The following is a description of a gene set: Human Gene Set: HARALAMBIEVA_PBMC_FLUARIX_AGE_50_74YO_CORR_WITH_28D_MEM_B_CELL_RESPONSE_AT_28DY_LATE_GENE_EXPR_INDIVID_GENE_MODELS_PRED_PEAK_B_CELL_ELISPOT_RESP_POSITIVE studied in species Homo sapiens from publication Haralambieva IH, Ovsyannikova IG, Kennedy RB, Zimmermann MT, Grill DE, Oberg AL, Poland GA (PMID 27317456) BACKGROUND: Studies suggest that the recall-based humoral immune responses to influenza A/H1N1 originates from activated memory B cells. The aim of this study was to identify baseline, early and late blood transcriptional signatures (in peripheral blood mononuclear cells/PBMCs) associated with memory B cell response following influenza vaccination. METHODS: We used pre- and post-vaccination mRNA-Seq transcriptional profiling on samples from 159 subjects (50-74years old) following receipt of seasonal trivalent influenza vaccine containing the A/California/7/2009/H1N1-like virus, and penalized regression modeling to identify associations with influenza A/H1N1-specific memory B cell ELISPOT response after vaccination. RESULTS: Genesets and genes (p-value range 7.92E(-08) to 0.00018, q-value range 0.00019-0.039) demonstrating significant associations (of gene expression levels) with memory B cell response suggest the importance of metabolic (cholesterol and lipid metabolism-related), cell migration/adhesion, MAP kinase, NF-kB cell signaling (chemokine/cytokine signaling) and transcriptional regulation gene signatures in the development of memory B cell response after influenza vaccination. CONCLUSION: Through an unbiased transcriptome-wide profiling approach, our study identified signatures of memory B cell response following influenza vaccination, highlighting the underappreciated role of metabolic changes (among the other immune function-related events) in the regulation of influenza vaccine-induced immune memory. Genes positively correlated with memory B cell response at 28d in peripheral blood mononuclear cell in seniors (50-74) after exposure to Fluarix, time point 28D. Comment: D: Late gene expression individual gene models (predicting peak B cell ELISPOT response) for module 11 (D, MSE=2.062), and this is the list of marker genes: IFNAR2, SIGLEC6, TIGD3 (NCBI Gene Id 220359), ZNF746, C1QC, SH3RF3, ANXA1, SCML2, RASSF8, SEZ6, ZC3H10, AJAP1, DSG2, MKNK2, LRRC58, XPR1